Given this list of marker genes NOTCH3, THSD1, MUC4, ADAMTS3, DAG1, ADAMTS4, ADAMTS19, GALNT12, MUC1, B4GAT1, THSD7A, ADAMTS7, THBS1, NOTCH4, ADAMTSL4, ADAMTS16, ADAMTS10, ADAMTSL5, GALNT3, ADAMTS2, MUC15, ADAMTS9, MUC21, NOTCH2, LFNG, MUC7, ADAMTS12, SEMA5B, NOTCH1, MUC5B, MUC17, ADAMTS6, ADAMTS14, ADAMTS13, CFP, MUC12, ADAMTS17, THSD7B, ADAMTSL2, ADAMTS8, POMT2, MUC6, ADAMTS5, MUC16, ADAMTS1, SPON2 (spondin 2), MUC3A, SEMA5A, THBS2 (thrombospondin 2), MUC13, SBSPON, LARGE1, POMT1, C1GALT1C1, THSD4, ADAMTS18, ADAMTS20, MUC20, C1GALT1, ADAMTSL1, B3GLCT, ADAMTSL3, SSPOP, ADAMTS15, POMGNT1, SPON1, MUCL1, MUC5AC, here is a description of the gene set: Human Gene Set: REACTOME_DISEASES_ASSOCIATED_WITH_O_GLYCOSYLATION_OF_PROTEINS studied in species Homo sapiens Diseases associated with O-glycosylation of proteins